Given this list of marker genes BTC, SKIC8, IL36G, PAWR, SH2B3, TLN2, MDFI, PEX12, MYH14, TMED2, PARP2, GCNT3, PRDM8, CTIF, MAPK11, PTPN13, ANO3, GOLGA2, DDX31, LRRC8E, NPHP4, SLC46A3, DGKE, PATZ1, NSDHL, NEMF, RAD21L1, NXPH3, GK2, CXCL2, ADCY1, TFCP2, C1orf54, KLF7, SPATS2L, MTA1, USP29, CITED2, PDS5A, GGA1, PRPF19, PSD4, DPY19L1P1, MDM2, RPL23AP32, ITGB4, TOR3A, PNLIPRP2, PLA2G2F, KRT8, CDON, SPARCL1, MICU1, NUP205, PLN, PROCR, STC1, RAB11FIP4, TUBGCP4, GLRX3, PAQR5, TUT4, FOXN3, FBXL12, DCTN6, CXCL14, P2RX7, GRM7, ANO10, SCML1, FLII, FCHSD2, SYMPK (symplekin scaffold protein), CDT1, ST6GAL1, SCLY, HPS4, LDB3, SPSB3, AGRN, CFLAR, GGNBP2, MTA2, SDHA, NCBP2, FGF6, SATB2, LPGAT1, KLHDC3, SOBP, MRPS18C, CACNB3, TNC, KAZN, GRK4, GJB3, CLTB, ZNF711, SARAF, NIPSNAP2, WDR47, NCK2, SMARCA2, EXOSC8, ULK1, SLC16A3, CCAR2, IDH3B, SERPINI1, FAM182B, FGD6, GMDS, GABPB1, ACKR2, RGN, ARVCF, PAPPA, RSL1D1, PPP1R11, EMILIN2 (NCBI Gene Id 84034), MTSS2, ZNF701, REM1, TRAK1, CA8, CD209, CSNK1G1 (NCBI Gene Id 53944), ARID3A, NDUFS2, FLRT1, CALCR (NCBI Gene Id 799), GABRB3, IFT70A, ARHGEF16, RARB, SNTB1, UBTF, NFKBIB, KANK2, TMEM63A, PXDN, NOX1, PLSCR3, CNOT1, TRPV4, SLC22A3, NSMCE4A, HABP4, WSB1, TFCP2L1, DSG2, NOL9, CEP170, EIF2D, ZNF551, OSBPL9, SS18L1 (SS18L1 subunit of BAF chromatin remodeling complex), ARIH2, LTBR, KRT20, UGT2B4, SLC1A4, CDK5RAP3, UCP3, FBXW2, RASL12, LGMN, OGFR, ETS1, THG1L, RSU1, GNAT2, GLT8D1, OLAH, POMGNT1, PCBP2, CZIB, NDST1, ATP11A, CLEC11A, AKAP10, SQSTM1 (sequestosome 1), XRCC6, SLC8A1, FAM120A, WDR45B, CST6, PBRM1, JTB, MIEF1, HGH1, IL6, HMGCS1, ANKRA2, PIGK, CSF2, OR7C1, KRT33A, PRKCSH, here is a description of the gene set: Genes down-regulated in HEK293 cells at 6h after stimulation by muramyl dipeptide: over-expressing mutant NOD2 versus control. Human Gene Set: GSE22611_MUTANT_NOD2_TRANSDUCED_VS_CTRL_HEK293T_STIMULATED_WITH_MDP_6H_DN NOD2 is an intracellular receptor for the bacterial cell wall component muramyl dipeptide (MDP) and variants of NOD2 are associated with chronic inflammatory diseases of barrier organs e.g. Crohn disease, asthma and atopic eczema. It is known that activation of NOD2 induces a variety of inflammatory and antibacterial factors. The exact transcriptomal signatures that define the cellular programs downstream of NOD2 activation and the influence of the Crohn-associated variant L1007fsinsC are yet to be defined. To describe the MDP-induced activation program, we analyzed the transcriptomal reactions of isogenic HEK293 cells expressing NOD2wt or NOD2L1007fsinsC to stimulation with MDP. Importantly, a clear loss-of-function could be observed in the cells carrying the Crohn-associated variant L1007fsinsC, while the NOD2wt cells showed differential regulation of growth factors, chemokines and several antagonists of NF-κB, e.g. TNFAIP3 (A20) and IER3. from publication Billmann-Born S, Till A, Arlt A, Lipinski S, Sina C, Latiano A, Annese V, Häsler R, Kerick M, Manke T, Seegert D, Hanidu A, Schäfer H, van Heel D, Li J, Schreiber S, Rosenstiel P (PMID 21335489) species: Homo sapiens